The following is a description of a gene set: species: Homo sapiens Human Gene Set: MIR4501 from publication Chen Y, Wang X (PMID 31504780) Genes predicted to be targets of miRBase v22 microRNA hsa-miR-4501 in miRDB v6.0 with MirTarget v4 prediction scores > 80 (high confidence targets)., and this is the list of marker genes: SYT17, ANGPTL3, DCUN1D1, BTAF1 (B-TFIID TATA-box binding protein associated factor 1), MYBL1, ANKRD18A, EFNB2, CBX6, SPRED1 (sprouty related EVH1 domain containing 1), TIFA, MPRIP, HSD11B1 (NCBI Gene Id 3290), CLU, TXNDC16, LRRC2, CCDC117, OSMR, EXOSC3, PPP2R2B, APBB2, NPAS3, CCPG1, CIMIP6, UBE4A, CPE, RACGAP1, TMEM184B, RIT1, ASXL2, IRAG1, SLC35A3, KATNAL1, ICE2, CA10, SARNP, ABTB2, CFAP58, HCN1, YME1L1, PURG, AVPR1A, CENPJ, ZFAND1, DYNC2I1, GK, SLC49A4, SPPL3, TMEM14A, UBE4B, FBXO6, ZBTB20 (zinc finger and BTB domain containing 20), CAPS2, STAT1, MIPOL1, KDM7A, FSD1L, DNAJA2, AGTR1, NKX3-1, ABR, ZNF501, MMAB, MCIDAS, DEFB118, TRIQK, PIK3C2A, CCNT1, NR5A2, TMEM248, CISD1, NAAA, ADAMTS6, KLF10, CREB1, PAQR9, TUBGCP3, FEM1C